Given this list of marker genes Slamf1, Ext1, Asb2, Calr, Tnfsf18, Spi1, Ccl19-ps3, Nlrp12, Ccl19, Slamf9, Ccl19-ps1, Ccl21b, Trpm4, Alox5, Slamf8, Eps8, Ccl21d, Ccr6, Cdc42, Ccl21e, Dock8, C1qbp, Retnlg, Gpr183, Ccl21f, Ccl21a, Trpm2, Il12a, Ccr7, Arhgef5, Ccl19-ps5, Ano6, Ccl19-ps6, Ccl19-ps4, Gas6, here is a description of the gene set: species: Mus musculus Mouse Gene Set: GOBP_DENDRITIC_CELL_MIGRATION The movement of a dendritic cell within or between different tissues and organs of the body.